The following is a description of a gene set: Catalysis of the transfer of an amino-acyl group from one compound (donor) to another (acceptor). Mouse Gene Set: GOMF_AMINOACYLTRANSFERASE_ACTIVITY studied in species Mus musculus, and this is the list of marker genes: Trim75, Rnf186, Ankib1, Trim63, Pin1rt1, Rnf139, Herc2, Marchf6, Trim55, Qpct, Rffl, Med7, Marchf5, Trib1, Msl2, Irf2bp1, Rbck1, Mgrn1, Ubr5, Tnfaip1, Trim7, Rnf220, Ube2srt, Peli2, Bcor, Birc5, Rc3h2, Rnft1, Nsmce2, Rfwd3, Trib3, Rnf169, Ube2s, Smurf2, Ube2r2, Fzr1, Ercc8, Siah1b, Cbx4, Btrc, Marchf2, Glmn, Trib2, Trim43c, Ppil2, Amfr, Rnf26rt, Rps15, Birc3, Vps18, Magel2, Dtx3l, Mdm4, Gid4, Ggt7, Anapc11, Rspry1 (NCBI Gene Id 67610), Ube2f, Trim40, Siah1a, Trim3, Trim44, Ubr2, Ube2v1, Rmnd5a, Ubr1, Rnf125, Toporsl, Rnf121, Pias3, Trim71, Asb1, Katna1, Rnf43, Triml2 (tripartite motif family-like 2), Rnf113a2, Peli3, Fbxl3, Cul4a, Klhl42, Med20, Ttc3, Trim45, G2e3, Trim9, Lnx2, Rnf130, Rnf44, Pml, Rnf213, Rnf145 (ring finger protein 145), Ube2j1, Ufc1, Ube2dnl1, Rnf183, Traf2, Kcmf1, Ube4a, Ube2d3 (ubiquitin-conjugating enzyme E2D 3), Trim50 (NCBI Gene Id 215061), Siah2, Rc3h1, Nccrp1, Cdc20, Fbxo40, Rnf133, Cdkn1b, Mib2, Traip, Rnf19b, Klhl20, Med24, Hdac4, Rnf34, Rnf26, Birc6, Trim11, Trim28, Rpl11, Ube2d4 (ubiquitin-conjugating enzyme E2D 4), Med12, Hectd2, Trim17, Mycbp2, Sharpin, Vps11, Jade2, Wsb1, Zfp451, Entrep1, Maea, Znrf4, Rnf112, Dtx1, Chfr, Ube2l3, Rnf7, Neurl1a (NCBI Gene Id 80633), Trim31, Traf5, Ranbp2, Rnf141, Rag1, Fbxo17, Tgm3, Rchy1, Cbl, Rnf144b, Park7, Rpl23, Dtx3 (deltex 3, E3 ubiquitin ligase), Rnf115, Atg10, Ube2c, Shprh, Rnf38, Fbxo11, Trim41, Hectd3, Ggt1, Marchf7, Ube2q2, Ube2k, Hecw1, Rnf182, Trim14, Zmiz2, Pja2, Trim34a, Trim6, Trim8, Pcgf2, Rnf225, Trim32, Bard1, Neurl1b, Hltf (NCBI Gene Id 99533), Fbxo15, Rnf223 (ring finger 223), Prkn, Med6, Asb12, Med18, Rnf212, Trim13, Rnf216, Zfp91, Rnf180, Traf6, Marchf8, Rnf128, Trim21 (NCBI Gene Id 20821), Cdc20b, Siah3, Rnf208, Fbxw8, Med10, Brap, Hace1, Mylip, Marchf3, Trim72, Tgm4, Rnf7l, Sumo2, Hdac6, Pex12, Fbxo30, Rnf40, Rnf113a1 (NCBI Gene Id 69942), Birc7, Trim59, Epb42, Bspry, Marchf1, Cnot4, Trim10, Ube2i, Rad18, Rnf167, Cdk8, Trim30d, Med31, Rnf215, Cul1, Trim15, Smurf1, Ube2g1, Trim12a, Pex2, Rnf138, Fancl, Cracr2b, Rnf227, Rnf181, Egr2, Birc2, Rnf14, Ube2t, Ring1, Ube3c, Fbxl22, Rmnd5b, Rnf4, Ggt5, Trim69, Ube2ql1, Rnf114, Rnf135, Ark2c, Brca1, Rnf187, Rpl37rt, Rnf41, Rnf214, Atg12, Trim61, Znrf2, Rnf152, Rnf138rt1, Rnf148, Mex3c, Ppp1r11, Rnf157, Cbll1 (Casitas B-lineage lymphoma-like 1), Med11, Cbx8, Pcgf5, Marchf11, Traf3ip2, Trim30b, Trim39, Rnf166, Ube2dnl2, Zfp598, Rnf103, Tgm6, Pias2, Rnf146, Trim27, Ube2g2, Med21, Ube2d2b, Ube2z, Rps20, Ube2o, Ube2d1, Fbxw7, Arel1, Ddb2, Rnf2, Pin1, Rnf126, Rnf111, Nt5c2, Ltn1, Rpl5, Wwp2, Rnf19a, Tgm5 (transglutaminase 5), Hecw2, Rnf168, Rnf20, Pten, Mkrn3, Dtx2, Ube4b, Pias4, Mib1, Pcgf3, Cop1, Ube2l6, Rnf217, Trim26, Kctd13, Trip12, Tgm7 (NCBI Gene Id 640543), Ube3a, Ubr3, Med1, Ube2n, Trim37, Trim36, Rnf8, Rnf11, Mkrn1, Triml1, Fbxo27, Dtl, Tnfaip3, Kctd10, Ccnc, Arih1, Rabgef1, Trim56, Neurl2, Rps7, Fbxo5, Malt1, Ufl1, Nedd4l, Med17, Cul3, Rbbp6, Uhrf1, Rpgr, Trim38 (tripartite motif-containing 38), Rlim, Ube2j2, Rnf5, Znrf1, Fancf, Trim24, Ube2e1, Ubr4, Traf7, Rnf10, Neurl3, Trim68, Trim23, Ark2n, Herc4, Tmem129, Ube2w (NCBI Gene Id 66799), Prpf19, Rnf170, Wdsub1, Syvn1, Cblb, Ube2a, Trim25, Trim34b, Trim47, Sh3rf2, Spry2, Fbxo2, Ubr7, Cdc34, Map3k1, Dtx4, Zzef1, Mkrn2, Wdr24, Tgm1 (NCBI Gene Id 69510, transglutaminase 1, K polypeptide), Cblc, Rfpl4, Zswim2, Trim33 (tripartite motif-containing 33), Rnf13, Ubox5, Rnf144a, Trim30c, Sh3rf1, Pias1, Ube3d, Uhrf2, Gbp4, Mefv, Klhl21, Tgm2, Med23, Fbxo44, Med27, Pex10, Ccnb1ip1, Sh3rf3, Taf1, Trim52, Dzip3, F13a1, Ube2frt, Zmiz1, Mul1, Asb4, Marchf9, Ube2q2l, Trim65, Atg3, Nhlrc3, Ube2e2, Trim35, Topors, Hectd1, Rnft2, Ggt6 (gamma-glutamyltransferase 6), Rnf149, Nosip, Sumo3, Irf2bpl, Xiap, Lrsam1, Mdm2, Rnf6, Asb2, Trim54, Bfar, Skp1, Limk1, Rnf31, Atg5, Trim5, Neurl4, Ube2e3, Aktip, Stub1 (STIP1 homology and U-Box containing protein 1), Trim30a, Ube2h, Rpl37, Rnf185, Arih2, Ube3b, Herc6, Ube2b, Rnf212b, Lonrf2, Med30, D7Ertd443e, Fbxl14, Rbx1-ps, Itch, Ube2q1, Huwe1, Ube2u, Dcst1, Nedd4, Traf3, Trim58, Ube2d2a, Klhl13, Aurkaip1, Trim43b (tripartite motif-containing 43B), Herc3, Fbxo4, Pdzrn3, Trim62, Otub1, Rnf25, Htra2, Pja1, Rnf150, Trim2, Klhl9, Cdkn2a, Rnf122, Cdc42, Obi1, Ube2m, Nhlrc1, Gcn1, Ate1, Uba7, Nsmce1, Bmi1, Rnf123 (ring finger protein 123), Trim60, Peli1, Znrf3, Fbxo6, Qpctl, Rbx1, Rnf39, Lnx1, Trim43a, Wwp1, Cdc34b, Marchf4, Trim12c, Fbxw11, Nfx1